The following is a description of a gene set: Abnormal epiphysis morphology of the phalanges of the hand studied in species Homo sapiens Human Gene Set: HP_ABNORMAL_EPIPHYSIS_MORPHOLOGY_OF_THE_PHALANGES_OF_THE_HAND Abnormality of one or all of the epiphyses of the phalanges of the hand. Note that this includes the epiphysis of the 1st metacarpal. In contrast to the metacarpals 2-5, the first metacarpal is embryologically of phalangeal origin and as such equivalent to the proximal phalanges of the digits 2-5 (whereas the proximal phalanx of the thumb is equivalent to the middle phalanges of the other digits)., and this is the list of marker genes: IFT140, PRKAR1A, ERCC8, ERCC6, COMP, EVC, MIR140, FGFR3, BMPR1B, EVC2, MRPS28, GPX4, TRPV4, KIF15, NPR3, TRIP11, COG4, COL2A1, RAB23, RUNX2, ATR, KCNH1, EIF2AK3, SRCAP, NEK1, IFT172, RMRP, NPR2 (NCBI Gene Id 4882), DYM, TRAPPC2, IHH, IFT52, RAD21, TONSL, MIA3, ARSL, FLNA, TRPS1, BGN, EXT1, GDF5, MGP